The following is a description of a gene set: Genes up-regulated in comparison of CD4+ CD8+ thymocytes versus CD4- CD8+ thymocytes. Mouse thymocytes can be classified into four major subsets based on expression of CD4 and CD8 co-receptors. CD4-CD8- (double negative, DN) cells become CD4+CD8+ (double positive, DP) cells following productive T cell receptor (TCR) beta chain rearrangement. A small proportion of DP cells are selected through interaction of clonal TCRalpha/beta and MHC self peptide complex expressed on thymic stromal cells. DP cell expressing MHC class I-restricted TCR become CD4-CD8+ cells, which will finally differentiate into cytotoxic T cells, while MHC class II restricted selection generates CD4+CD8- helper lineage T cells. We used microarrays to identify genes important for thymocyte differentiation and lineage determination by profiling gene expression in different thymocyte subsets. Human Gene Set: GSE31082_DP_VS_CD8_SP_THYMOCYTE_UP species: Homo sapiens from publication Egawa T, Littman DR (PMID 21873191), and this is the list of marker genes: CENPC, TOB1, DCTN4, GDPD1, YTHDF3, CTDSPL2, CDC5L, ETAA1, ABI1, USP1, PATZ1, ZCCHC8, CCDC28B, DEXI, TMPO, SORD, REPS1, TRAK2, ZBED6, STX6, PTPN14 (protein tyrosine phosphatase non-receptor type 14), VIRMA, LANCL2, KCTD1, ERRFI1, HMG20A, EGFL8 (EGF like domain multiple 8), E2F7, SSX2IP, REEP4, ZBTB41, CPSF7, DUT, ALDH2, ANGPT1, TTPAL, SCN4B, DMWD, HNRNPR, SECISBP2L, NAPG, TRIM39, IFT81, MYL11, PAFAH1B2, SMARCD2, ATF1, HES6, CACNB3 (calcium voltage-gated channel auxiliary subunit beta 3), UBA3, ATRNL1, HDAC7, LAPTM4B, DEPDC1, CYB5A, SNRNP35, RNF26, EHMT2, PAIP2, PDE5A, SPC25, WDTC1, AKT1, EZR, KLHDC10, CSRNP2, ZNF664, DIP2A, SRGAP2, BCL7A, TTC12, NEK2 (NCBI Gene Id 4751), H2BC13, PTGR1, KLHL24, SLC37A2, TSC22D4 (NCBI Gene Id 94778), SUPT20H, LRRC1, LAG3, GPR132, SLC30A9 (NCBI Gene Id 10463), LSM14B, PPP4R3B, FEM1B, CEP290, POLA1, SLK, SPRTN, CEP70, FHIP2B, NPLOC4, RCSD1, ZBTB33, PPP2R5D (NCBI Gene Id 5528), YTHDC2, BLM, DMXL1, EIF4E3, SLC30A4, BNIP2, TSC22D2, LDB1, GTF3C5, ARHGEF39, DLGAP5, H2AZ1, ETS1, CPNE1, MSH6, TRIM11, SYNJ2BP, FOXO4 (NCBI Gene Id 4303), PAFAH1B3, MYO1C, MEGF9, E2F8, UEVLD, FBXO45, TLE2, ZNF704, SGO2, CLK4, PLK1, RGS12, FAM193B, XPO4, APPBP2, RRM1, WDR27, UBE2E3, SMC4, PCGF3, PSD4, TP53INP1, CELF1, TMEM167B, LCK, ESCO2 (NCBI Gene Id 5951), MACIR, NETO2, PPP1R21, INTS8, ZNF740, SLC4A2, MBNL3, RNF20, METAP2, RSF1, MOB1B, AKIRIN2, BRD9, RIPOR1, ICAM2 (NCBI Gene Id 3384), DEK, RB1CC1, TRIM44, MAD2L1, VHL, CD247, TUBGCP3, UMAD1, CTSV, TCEAL9, FAM117A, NUDT4, DLG3, TOP1 (DNA topoisomerase I), DIPK2A, PALS1, SMC5, TUBB, SKA2, MTMR14, PBK, DNAL4, EDC3, RCBTB2, PHC1, KDM3B, SLC38A9, MDM4, NUSAP1, PURG, PPP1CC, RTN4, NPHP1, AURKA, DYRK1A, CEP170, SSH3, JADE3, FADS2, PAN2, PRDX2, YBX2, MYO18A, ELOA, THRAP3, SLC35E3 (solute carrier family 35 member E3)